The following is a description of a gene set: Human Gene Set: GSE16385_MONOCYTE_VS_12H_ROSIGLITAZONE_TREATED_MACROPHAGE_UP Human CD14 positive monocytes were purified from healthy volunteers’ blood and cultured in vitro for 4, 12, 24, 72 hours. While culturing, macrophages were activated alternatively with interleukin-4 (IL-4 100 ng/ml) or classically with interferon-gamma (IFNg 100 ng/ml)+tumor necrosis factor (TNF 50 ng/ml) or left without activation. Simultaneously, macrophages were also treated with vehicle (DMSO:ethanol) or 1mM synthetic PPARg agonist, Rosiglitazone. We used Affymetrix microarrays (U133Plus 2.0) to analyze activation and PPARg-induced gene expression changes. from publication Szanto A, Balint BL, Nagy ZS, Barta E, Dezso B, Pap A, Szeles L, Poliska S, Oros M, Evans RM, Barak Y, Schwabe J, Nagy L (PMID 21093321) Genes up-regulated in monocytes (12h) versus macrophages (12h) treated with rosiglitazone. species: Homo sapiens, and this is the list of marker genes: COA6, RLN1, PNO1, KYAT3, NDUFA12, PDHB (pyruvate dehydrogenase E1 subunit beta), PGK1, PEX7, BIRC3, MAST4, GAPVD1, DLX4, PCDH9, ATP5ME (NCBI Gene Id 521), ZNF292, OSCAR, SHROOM4, GRPEL1, SPARC, EVI5, STARD6, CNGA4, GLG1, LSM3, USP53, GABRG3, IGFBP5, CPD, HOXB3, RPL23, CYB5R2, IL17RE, URGCP, CPA5, SYNPR, APEX1, MIR1915HG, ZNF420, NPHS2, G6PC1, JAGN1, CA1 (carbonic anhydrase 1), CASKIN1, GPC5, TGFB2, CEMIP2, DZIP1, IDH3A, AKR1B1, TASOR2, HPRT1, COPS6, CNOT6, FMO1, ARFGEF3, HOXC8, FRMPD3, ATPAF2, EPRS1, TRAPPC6B, EPHA5, CXorf58, RPL37A, SLC6A18, HEATR1, KIF24, CFI, MRPL15, SLC39A12, HSD17B1, NCKAP5, NRSN1, NRIP1, DPT, NUDT21, FANK1, RTRAF, GRM5, GPRC5A (G protein-coupled receptor class C group 5 member A), MID1, NOL7, CARD10, BNIP3L, SLC6A20, E2F5, ETFA, TMC1, DIS3L2, URI1, ATP5F1C, RAPGEF6, CENPN, IL18 (NCBI Gene Id 3606), NAP1L3 (nucleosome assembly protein 1 like 3), TMEM167A, BOK, MTDH, ADAMTSL2, SAP18, LAGE3, LACC1, UBE2F, RBM20 (RNA binding motif protein 20), POLR1F, FGL1, SYNJ2BP, KCNJ11, SLC17A3, SCML2, CMC2, DOCK1, MRPL13, ATAD3A, SPEG (striated muscle enriched protein kinase), CCNJL, PUM3 (NCBI Gene Id 9933), RANBP3L, GPD2, RPL12, OR7C1, EIF3E, STEEP1, SLC1A2, STARD9, SLFN12L, RASGRP3, CYP4B1, UQCRC2, JAM2, LRRC19, PIWIL1, CWC22, POU5F2 (NCBI Gene Id 134187), MEOX1, METTL2B, TSPAN32, MARCHF3 (membrane associated ring-CH-type finger 3), LYPLAL1, PAN3, GTF2H5, GART, EHD2 (EH domain containing 2), UNC5C, LSM4, TFB2M, BPGM, ZNHIT3, ANKRD7, FLJ13224, PROM1, SMIM15, CLIP1, COPB2 (COPI coat complex subunit beta 2), GLYCTK, SDC2, MFAP3, NDUFB11, NDUFA2, TOMM7, MRPL20, DUSP18, DDX54, ZDHHC20, SEPTIN10, NANP, DDX3X, COL8A1, SEC61B, AKR1D1, HTRA3, ARAP2, ZNF493, SLC34A2, BZW2, PPM1B, AQP9, SNRPF, IQSEC2, CHRNA6, RAB3A, RPP30, RPTN, VWC2L, WEE1, KRIT1, MREG, CSF3 (colony stimulating factor 3), GCSH, GGT5, SNX29, UQCR10, LRRC56, NAP1L5, RPS27L, COX7B2, POM121L2, SMIM11, GABRB1, NDUFB8 (NCBI Gene Id 4714), LRRTM4